The following is a description of a gene set: Anti-apoptosis. species: Homo sapiens Human Gene Set: MODULE_537, and this is the list of marker genes: TNFAIP3, BCL2A1, IL1A, BIRC3, CFLAR, NRG2, IER3, BCL2L1 (NCBI Gene Id 598), SERPINB2, SEMA4D, SON, NFKB1, BIRC2, BIRC5, CD2, BNIP3, MYBL2